The following is a description of a gene set: Human Gene Set: HP_EMBRYONAL_RHABDOMYOSARCOMA Embryonal rhabdomyosarcoma studied in species Homo sapiens, and this is the list of marker genes: MAD1L1, BUB1B, DICER1, NF1 (NCBI Gene Id 646021), SLC22A18 (solute carrier family 22 member 18)